The following is a description of a gene set: Mouse Gene Set: GOBP_DNA_TEMPLATED_DNA_REPLICATION A DNA replication process that uses parental DNA as a template for the DNA-dependent DNA polymerases that synthesize the new strands. species: Mus musculus, and this is the list of marker genes: Dynll1, Prim2, Mcm4, Orc5, Twnk, Gins1, Orc4, Prim1, Ddx11, Eme2, Orc3, Nucks1, Orc1, Polq, Mms22l (NCBI Gene Id 212377), Aicda (activation-induced cytidine deaminase), Brca2, Tipin, Ino80, Baz1a, Zmpste24, Mgme1, Exd2, Mettl4, Atg7, Ciz1, Wrn, Cdk2, Brca1, Rfc2, Pola2 (NCBI Gene Id 18969), Wdr18, Mcm10, Mtnap1, Donson, Rny1, Wrnip1, Rtel1, Rbbp8, Kat7, Gins2, Lig3, Eme1, Ilkap, Rad51, Traip, Mcm5 (NCBI Gene Id 194478), Dbf4, Polrmt, Pole3, Poln, Senp2, Cenps, Pold3, Polg2, Rrm1, Pole, Pold2, Smarcal1, E2f7, Endog, Fam111a (NCBI Gene Id 68258), Blm, Mcm6, Carm1, Zfp830, Noc3l, Atrx, Gmnn, Fancm, Khdc3, Rrm2b, Dnaja3, Nbn, Upf1, Pcna, Fgfr1, Orc2, Rpain, Zpr1, Ooep, Primpol, Asf1a, Mcm7, Ssbp1, Rfc5, Rfc4, Cenpx, Setmar, Cdc6, Pold4, Exo1, Mcidas, Rad50, Ager, Mcmbp, Lig1, Pole2, Gins3, Cdc45, Wdhd1, Recql5, Polg, Rny3, Bard1, Bod1l, Mcm2, Ticrr, Fbxo5, Atr, Gins4, Tk1 (thymidine kinase 1), Gen1, Dach1, Rtf2, Pola1, Rnaseh1, Etaa1, Gmnc, Samhd1, Mcm3, Fbh1, E2f8, Tonsl, Atad5, Ccne2 (NCBI Gene Id 12448), Mcm9, Nuggc, Ccne1, Dna2, Orc6, Chrac1, Wiz, Cdc7, Zranb3, Topbp1, Mus81, Rfc1, Cdk9, Rfc3, Mre11a, Zfp365, Pole4, Pold1, Recql, Helb, Timeless, Parp1, Tk2, Cdt1, Rfwd3